Given this list of marker genes IL7, FASLG, CD8A, TLR1, CD3G, APC, here is a description of the gene set: species: Homo sapiens from publication Panapasa JA, Cox RJ, Mohn KG, Aqrawi LA, Brokstad KA (PMID 26148331) Human Gene Set: PANAPASA_BLOOD_FLUENZ_AGE_03_17YO_3DY_4DY_DN Genes down-regulated in blood 3d and 4d vs 0d in children (3-17) after exposure to Fluenz (LAIV), time point 3D and 4D (merged), administered i.n. Live attenuated influenza vaccines (LAIV) can prevent influenza illness and death in children. The absence of known correlates of protection induced by LAIV requires human studies of underlying mechanisms of vaccine-induced immunity, to further elucidate the immunological processes occurring. In this study, children scheduled for elective tonsillectomy were enrolled in a clinical trial to evaluate the immune response to LAIV, in order to compare T and B cell gene expression profiles. Twenty-three children (aged 3-17 years) were divided into 4 groups; unvaccinated controls, or vaccinated intranasally with LAIV at days 3-4, 6-7, and 12-15 before tonsillectomy. Total RNA extraction was performed on tonsillar tissue and high RNA quality was assured. The samples were then analyzed using a validated RT2 Profiler PCR Array containing 84 gene-specific primers involved in B and T cell activation, proliferation, differentiation, regulation and polarization. The gene expression after LAIV vaccination was subsequently compared to the controls. We observed that at d 3-4 post vaccination, genes were down-regulated, namely APC, CD3G, FASLG, IL7, CD8A and TLR1. Meanwhile at 6-7 days post vaccination, genes were significantly up-regulated, including RIPK2, TGFB1, MICB, SOCS1, IL2RA, MS4A1, PTPRC, IL2 and IL8. By days 12-15 the genes RIPK2, IL4, IL12B and TLR2 were overexpressed. RIPK2 was upregulated at all 3 time points. Our data suggests an overall proliferation, differentiation and regulation of B and T cells in the tonsils following LAIV, where the majority of genes were up-regulated at days 6-7 and normalized by days 12-15. These findings may provide a first step into defining future biomarkers or correlates of protection after LAIV immunization.